The following is a description of a gene set: EMG: positive sharp waves species: Homo sapiens Human Gene Set: HP_EMG_POSITIVE_SHARP_WAVES These are spontaneous firing action potentials stimulated by needle movement of an injured muscle fiber. There is propagation to, but not past, the needle tip. This inhibits the display of the negative deflection of the waveform., and this is the list of marker genes: ANXA11, SGCG, SETX, MTMR14, TFG, GNE, OPTN, NR4A2, DNM2